The following is a description of a gene set: Genes down-regulated in comparison of dendritic cells (DC) stimulated with Gardiquimod (TLR7 agonist) at 0.5 h versus those stimulated with Gardiquimod (TLR7 agonist) at 12 h. studied in species Homo sapiens mouse primary BMDCs were stimulated with tlr ligands and gene expression changes were profiled on Affymetrix arrays from publication Amit I, Garber M, Chevrier N, Leite AP, Donner Y, Eisenhaure T, Guttman M, Grenier JK, Li W, Zuk O, Schubert LA, Birditt B, Shay T, Goren A, Zhang X, Smith Z, Deering R, McDonald RC, Cabili M, Bernstein BE, Rinn JL, Meissner A, Root DE, Hacohen N, Regev A (PMID 19729616) Human Gene Set: GSE17721_0.5H_VS_12H_GARDIQUIMOD_BMDC_DN, and this is the list of marker genes: GPR137B, ARL1, DMTN, TDRD7, EIF4G3, YY1, PMEPA1, RRS1, PELI1, NGRN, MAPK8, PSMB7, FAP, LUC7L, RNF145, CLRN3, TTC28, EED, CCNL2, DCN, SCYL1, ITPKB, UBE2M, PHF21A, COIL, HES5, METTL3 (methyltransferase 3, N6-adenosine-methyltransferase complex catalytic subunit), RAMP2, APAF1, ST3GAL1, PTK2, TLR8, GABRB1, TAPBP, SERINC1, NFKBIA, KLF3, VASP, SRSF11, POU2F1, G3BP2, RUSC2, PSMD5, MAN1A2, TRAF3IP2, CAMSAP1, GEM, SIGLEC7, IFI35, TBX3, GPSM2, PUM1, DNAJA1, MYEF2, MOB1A, PHF13, NUP62 (NCBI Gene Id 51551), CLNK, PAXBP1 (PAX3 and PAX7 binding protein 1), DPYS, AKR1A1, USP12, ARL14EP, EPDR1, MTG2, DSCAML1, ZNF260, GPR85, GRAMD1A, TMEM199, SLC25A25, TLR3, GLIPR1L2, TBC1D8B, B4GALT3, TMEM106B, RBM4, ICAM1, TMCO3, CSF3R, BBLN, KREMEN1, DTNB, PRDX5, PABIR1, PCMTD2, RFFL, VAV1, ZBTB1, UBE2D3, ANKRD40, SLC22A4, PIGN, KBTBD4, MORC3, HSPA1A, DLK1, SMG6, DLX1, UBE2Z (ubiquitin conjugating enzyme E2 Z), CAVIN4 (caveolae associated protein 4), H2AC25, GRIN1, RIPK2, MDFIC, DGKA (diacylglycerol kinase alpha), LRRC49, ZNF503, COPS2, ARMCX3, DUSP16, CASP8, M6PR, ZBED4, AGPAT3, IL10, ASTN1, HNRNPH3, SERPINB9, COG4, LYPD8, KCTD1, CYP2F1, CYP39A1, CLK3, RAP1B, MLX, NUDCD1, RAI14, FCER1G, PLXNA1, SERTAD3, ATP6V0B, UIMC1, TPP2, VWA1, LRRC8C, RAB33A, PXK, CLK4, SPG11, SNAPC3, HSD17B12, SOCS4, ASNS, SLC11A1, AZIN1, EDEM2, HPS3, NDRG1, MRPL14, ATAD1, P2RX7, HELZ2, FBXW11, IAH1, CCDC47, SRC, ACSL5, CD320, MYO1B, RNF11, TMEM243, RNF121, BLOC1S4, TUBB4B, RNF141 (NCBI Gene Id 50862), RASGRP1, TM9SF4, NR3C1, NLGN2, DNAJB1, TSC22D1, LHX2, PSMB5, YPEL5, PTGIR, USP47, CALCRL, PSMD10, TYMS, PTPRA, TAX1BP1, PRDX1, PRKRIP1, UPP1, NFKBIB, USP53, RBL1 (RB transcriptional corepressor like 1), ZZZ3, KLHDC3, ST7L, CX3CR1, NADK, RFX3, NUPR1, JDP2, JAK2, TET1, RNF34 (NCBI Gene Id 96268)